The following is a description of a gene set: A process in which a protein is transported to, or maintained in, a location within a membrane raft. studied in species Mus musculus Mouse Gene Set: GOBP_PROTEIN_LOCALIZATION_TO_MEMBRANE_RAFT, and this is the list of marker genes: Flot2, Cd24a (CD24a antigen), Clip1, L1cam, Negr1, Rftn1, Reep2, Myadm, Tsc2, Cyp46a1, Umod, Zdhhc2